Given this list of marker genes ABCB11 (NCBI Gene Id 8647), ABCB1, ABCG2, ABCA3, ABCC3, ABCC4, ABCC5, ABCC1, ABCC2, ABCC10, ABCA8, RALBP1, ABCB5, ABCC11, here is a description of the gene set: Human Gene Set: GOMF_ABC_TYPE_XENOBIOTIC_TRANSPORTER_ACTIVITY species: Homo sapiens Catalysis of the reaction: ATP + H2O + xenobiotic(in) = ADP + phosphate + xenobiotic(out).